Given this list of marker genes Nusap1, Camk2b, Msx2, Btc, Pdgfrb, Plcb1, Anapc7, Dmrt1, Tnf, Nsmce2, Egf, Stra8, Epgn, Sphk1, Cdc20, Wnt4, Cenpe, Rb1, Ins2, Rad51ap1, Nup62, Prap1, Cdc16, Sirt2, Mad2l1bp, Fbxo5, Pdgfb, Igf2, Il1b, Il1a, Lrp5, Npm2, Edn3, Ins1, Pebp1, Meiosin, Smpd3, Anapc5, Phip, Igf1r, Insr, Cul3, Ska3, Prdm9, Drd3, Igf1, Gja1, Fgf8, Tgfa, Wnt5a, Anapc11, Ube2c, Mad1l1, Piwil2, Rgcc, Cdc23, Met, Dazl (deleted in azoospermia-like), Ereg, Npr2, Ooep, Hoxa13, Sh2b1, Ska1 (NCBI Gene Id 66468), Msx1, Eif4g3, Cd28, Edn1, Ube2b, here is a description of the gene set: Any process that activates or increases the frequency, rate or extent of nuclear division, the partitioning of the nucleus and its genetic information. Mouse Gene Set: GOBP_POSITIVE_REGULATION_OF_NUCLEAR_DIVISION studied in species Mus musculus